Given this list of marker genes GTF2H5, UBR2, HCP5, TIMM10B, MTHFD1, CDC40, PLXNA2, POLD1, COL9A2, VPS13C, GOLGA1, PTPN22, LRRC8D, CREB3L2, ATM, DGLUCY, MDM1, THAP11, DUS4L, DERA, AKAP7, MAN2B2, SERPING1, REST, CSTPP1, NMRK1, DNAAF8, SLC25A12, CCR9, FAM8A1, LGALS2, PPP1CC, TTC13, CKS1B, ANGEL1, NDUFB5, RAB40AL, SPCS1, C1R, CETN3, MYDGF, RFC4, FHOD1, HLTF, SDF2L1 (stromal cell derived factor 2 like 1), FBXO5, SNAP91, SCLY, TAPBPL, FECH, CISD1, NDC1, MDH2, KCNMA1, DNMT1, IFFO1, CDK5, MLEC, TRAV12-2, FAN1, HERC1, TMEM164, BTN3A3, LY75, ACAT1, ZNF674, KLHL22, DNASE1L2, DDT, CKLF, CLCN3, MRPS33, NISCH, APOL1, LY86, DYNC2LI1, UCK2, SCP2, FKBP3 (FKBP prolyl isomerase 3), ITFG1, ERAP2, ANKMY2, UBAC1, LSM4, COX5B, RRP1B, RND2, BTN3A1, ASXL2, VPS45, CDH6, MRPL57, CD38, POLR3E, TBL2, ATP13A1, GALNT12, RUVBL1, CTR9, PCM1, ASS1, DNASE1L1, TKFC, VPS51, ACOT13, SOX18, NDUFS6, ADGRF1, PFKP, PEX3, TYW1, FRMPD4, ARPC1B, OGFOD3, CFB, TGM2, PER2, VAMP5, ZNF446, GALNT7, RNF170, SCRIB, WDR12, SMARCD3, NCAPD3, MVP, FASTKD1, UQCR10, HMBS, C1orf54, SEL1L, GNS, ARB2A, SRBD1, PPA2, PDIA3, ARF3, COCH, UBE2D4, LDHB, ALDH5A1, AASDHPPT, PSMB9, ARHGEF10, SLC37A4, H1-6, CCDC85B, UBE4B (NCBI Gene Id 10277), HLA-DRB1, SCN3A, SCPEP1, ATIC, RSU1, MAGEF1, LEP, MRPL34, PLAAT4 (NCBI Gene Id 5920), TRPM2, SP140, PSMB10, ACP2, BCKDHA, ZMAT3, CEP57, GATD3, MRPS28, SNX27, UTF1, NFX1, CARD9, TKTL1, ASB13, RHOT1, SMARCA2, PIGF, ATP5IF1, CDK2AP2, LGALS3BP, SNAPC5, PRPF31, ECD, LARS2 (NCBI Gene Id 23395), CASD1, METTL5, PARN, UROS, VPS11, ECHS1, HSPA14, HLA-DPB1 (major histocompatibility complex, class II, DP beta 1), SLC7A6, VPS41, ARHGEF3, OGG1, COX15, HLA-F, NIPSNAP1, UCHL5, CLNS1A, HLA-E, here is a description of the gene set: studied in species Homo sapiens Genes down-regulated in comparison of microglia cells 6 h after stimulation with IFNG versus microglia cells 24 h after the stimulation. Human Gene Set: GSE1432_6H_VS_24H_IFNG_MICROGLIA_DN from publication Rock RB, Hu S, Deshpande A, Munir S, May BJ, Baker CA, Peterson PK, Kapur V (PMID 16163375) Microglial cells are resident macrophages in the central nervous system (CNS) and play a pivotal role in the innate and adaptive immune responses against microbial infections. The immune functions of microglia are regulated by a milieu of cytokines including interferon (IFN)-gamma. We here performed a series of experiments to acertain the transcriptional profile of human fetal microglial cells at 1, 6, and 24 h after IFN-gamma treatment. Primary human microglial cells were either untreated or treated with 200u/ml IFN-gamma. Affymetrix U133A chips were utilized. Four different tissue samples (B18, O, W, and Y20) were analyzed at the three time points.